Given this list of marker genes Dnaaf9, Fsd1l, Acsl5, Nt5e, Rgs17, Tiparp, Wdr26 (NCBI Gene Id 98607), Tbl1xr1, Fam20c, Itprid2, Gem, Emc3, Gulp1, Onecut2, Etnk1, Zfp866, Ticam2, Ston2, Sytl5, Plcb1, Fas, Dr1, Gdi2, Atp13a3, Mpc1, Vasn, G3bp2, Rnaseh2b, Sowahb, Mbd6, Nr3c1, Hoxa9, Kncn, Gng5, Usp14, Myrip, Gapvd1 (GTPase activating protein and VPS9 domains 1), Prkag2, Slc4a4, Tmem123, Spdya, Sdsl, Map1b, Pck2, Sema3c, Kcnj6, Gpr85, Abhd4, Tmem47, C9orf72, Matr3, Phactr2, Selenoi, Med13, Man1a, Qsox2, Nexmif, Clock, Mindy2, Esrrg, Cnksr2, Sptssa, Srsf11, Parp14, Zfp518a, Tspan5, Slc19a3, Myh11, Ube2w, Dedd, Zfp280d, Spag17, Rps6ka3, Crym, Ifi208, Herc1, Negr1, Syt9, Palb2, Pdia6, Ap1ar, Tstd2, Cep72, Rragc, Manba, Irf1 (interferon regulatory factor 1), Capza2, Stxbp1, Cntd1, Cks2, Snx21, Ate1, Ikzf2, Sash3, Kbtbd11, Hnf1b, Zdhhc17 (zinc finger, DHHC domain containing 17), Ivl, Grb7, Dock5, Rasa1, Dusp6, Hyal6, Ptprg, Cers6, Tomm20, Stx8, Rimkla, Rfx3, Sox21, Pxdn, Ubtd2, Slc23a2, Prkci, here is a description of the gene set: species: Mus musculus Genes predicted to be targets of miRBase v22 microRNA mmu_miR_653_3p in miRDB v6.0 with MirTarget v4 prediction scores > 80 (high confidence targets). Mouse Gene Set: MIR_653_3P from publication Chen Y, Wang X (PMID 31504780)